The following is a description of a gene set: Mouse Gene Set: GOBP_RISC_COMPLEX_ASSEMBLY The process in which a single-stranded small RNA is incorporated within the RNA-initiated silencing complex (RISC). The assembly includes the maturation of the small RNA, the stabilization of the complex by accessory proteins of the RISC complex, duplex separation and the release of the second strand, forming a base-pairing complement complex that mediates gene silencing by small RNA. species: Mus musculus, and this is the list of marker genes: Tarbp2, Prkra, Dhx9, Adar, Ago2, Clp1, Ago3, Ago1, Ago4, Dicer1